The following is a description of a gene set: Genes containing one or more binding sites for (Pcgf3) in their promoter regions (TSS -1000,+100 bp) as identified by GTRD version 20.06 ChIP-seq harmonization. from publication Yevshin I, Sharipov R, Kolmykov S, Kondrakhin Y, Kolpakov F (PMID 30445619) studied in species Mus musculus Mouse Gene Set: PCGF3_TARGET_GENES, and this is the list of marker genes: Gm9758, Fbh1, Dnajb14, Ttc39d, 4930447C04Rik, Coprs, B3galt6, Gm15564, 5930430L01Rik, Rad9a, G730013B05Rik, Trip6, Tex101, Zc3h4, Atp6v0b, Rrn3, Dpp7, Dnajb9, Klhl22, Atp6v0d1, Natd1, Cib1, Hdac2, Cers6, Rpp38, A230060F14Rik, 6430548M08Rik, Scarna2, 4933434E20Rik, Hapstr1, Gm25894, Snhg9, Tmem108, Blm, Dcaf13, 8030453O22Rik, Vps26a, Ccdc103, Hoxa4, Prelid1, Osgep, Nup50, Rasgrf2 (NCBI Gene Id 70739), Cmc1, Mir5625, Rasa2, Gm12743, Fbxl2, Slc3a2 (solute carrier family 3 (activators of dibasic and neutral amino acid transport), member 2), Uhrf1, Fig4, Trim37, Gm16894, Pip4p1, Cdkl3, Atg14, Vps8, Uvrag, Aimp1, Ankrd16, Tgfa, Srsf2, Anxa6, Prmt9, Abhd17b, Snord2, Lamp1, Atp8b2, Tcam1, Synrg, Rnf130, Ighv8-14, Ubap2, Repin1, Gtf2h1, Podxl2, Aars1 (alanyl-tRNA synthetase 1), E2f6, Neurog1, Henmt1, Clcn6, Bnip3l, Pcx, Cep162, Dohh, Tmcc1, 1700122E12Rik, Hmox1 (heme oxygenase 1), Rnf212, Gpatch3 (G patch domain containing 3), Ubtd1, Orc4, Sumf1 (NCBI Gene Id 58911), Calcoco1, Tff3, Gstm2, A330048O09Rik, Rnf227, Pou2f1, Gm10555, Fam171b, Sf3b1, Gm8357, D430019H16Rik, 4930445N08Rik, Ttk, Mgam, Gm6288, Ip6k1, Hsd11b1, Dennd6a, Gba1 (glucosylceramidase beta 1), Chchd3, Zfp292, Gm11399, Npl, Gpc2, Pstpip2, Odad4, Prkar2a, Catsperg1, Tbck, mt-Co1, Bcas2, 2810408I11Rik, Hsf5, Platr30, Sub1, Gm25362, St6galnac3 (ST6 (alpha-N-acetyl-neuraminyl-2,3-beta-galactosyl-1,3)-N-acetylgalactosaminide alpha-2,6-sialyltransferase 3), Atg5, Fam178b, 1700001L05Rik, mt-Td, 6820431F20Rik, Spata31e2, Washc5, Nptn, Mettl5os, Bcl6, Scyl3, Echdc2, Ulbp1, Sec11c, Poldip3, Ddx5, Tdg, Ncl, Ccnb3, Ccar1, Clk4, Ighv1-67, Aspa, Micu1, Pbxip1, Piwil2, Atosa, Ctsb, Cln3, Cd164, Hspbap1, 3110082I17Rik, Mir7688, Sdf2l1 (NCBI Gene Id 64136), Lamtor5, Vapa, Commd4, Senp8, Satb2, Hoxd10, Fbxo25, C87436, Nr5a1, Fbxw4, Nup85, Psme3ip1, Neat1, 1700028E10Rik, Glb1, Prkacb, Srsf3, Myl12a, 4930535L15Rik, Mbtd1, Slc33a1, Stag3, Gm22711, mt-Tq, St13, Napa, Sgo1, Matr3, Ccdc115, Mapre1, Mir5627, Gm17259, Gm10463, Fkbp6, Prkcsh, Trpm7, Osbpl7, Sc5d, Tmem143, Cdk4, Mfsd1, Laptm4b, Agtrap, Tfap2c (NCBI Gene Id 98784), Stk4, Washc2, H2bc8, Med28, Glyr1, Phc3, Mtch1, Tmppe (transmembrane protein with metallophosphoesterase domain), Zfp280d, Csdc2, Ptprs, Ccdc124, Tex12, Alg1, Trpm8, Lcp2, Smap1, Gm16853, Ubb, Top1, Sec62, Exoc1, Tsen2, Mapk8, Khdrbs1, Atpaf2, Adgrv1, Atg13, Krt9, mt-Nd6, Nrxn1, 5830411K02Rik, Haus3, Boll, Commd8, Gpr176, Oas1b, G530011O06Rikx, Sdf4, mt-Tc, Wwp2, Rpl3, Rnu11, Gnpda1, Slc25a32, Nup188, Nrip3, Net1, Tdrkh, Relb, Selplg, Slc35a5, Gm19705, Ptp4a1, Lhfpl2, Rad50 (RAD50 double strand break repair protein), Smchd1, Mtch2, Cyba, Gm5893, Cox18, Ccdc13, Stmn1, Snora21, Dusp7, Bax, Alyref, 4930539M17Rik, Xpnpep3, Slc9a1, Depdc1b, Stt3b, Slc35g2, Ankrd24, Hmgn3, Mief2, Zfp747l1, Por, Rabl2, Cul5, Gm16675, Ctsl, Espl1, Vgf, Cc2d1a, Cnpy2, mt-Tm, Gm8379, Rhpn1, Mrpl27, Xrra1, 1700030C10Rik, Rnasek, Syngr4 (NCBI Gene Id 80661), Tex14, Otud1, Mir6978, Mks1, Zmiz1 (NCBI Gene Id 328365), Tbccd1, Phc2, mt-Nd5, Srd5a1, Cipc, Rbm19, 2310043M15Rik, Smim23, Gm2762, Fau-ps2, Gm2788, Zfp998, Slc49a4, Brme1, Deaf1, Vps33a, Rps28, Tnrc6c, Sppl3, 3000002C10Rik, Or4c119, Tmed2, Ctns, Meiosin, Lrrc27, Tmem19, Gad1, Zfp786, Zfp386, Hmgcl, Slc6a20a, Slc12a7, Harbi1, Ube2b, Imp4, Mir466j, Mir294, Begain, Or11m3, Paip1, Sae1, Haglr, Hdlbp, Fam241b, Tbc1d20 (TBC1 domain family, member 20), Mthfr, Pycr2, Rfesd, Itln1, Hspa9, Mei1, Cul3, Ttc3, Gm24016, Igfbp4, Pla2g12a (phospholipase A2, group XIIA), Ccnyl1, Kdm4c, Derl3, Kmt5c, Fndc3a, Togaram1, Spns1, Pxt1, Gm2093, Gdpgp1, Ppp1r3b, Bsg, Rragc, Gtf2a1, Tle6, Spin1, mt-Th, Stk25, Pcbp1, Tmem131, Kbtbd6, mt-Tv, Gm5067, Whrn, Dnase2a, Smyd4, Pdcd6ip, 4632404H12Rik, Amdhd2, Ighv12-2, 4930469K13Rik, Paxip1, Gmfb, Ybx2, Lmtk3, Rabl6 (RAB, member RAS oncogene family-like 6), Naxe, Dync1i1, 1600020E01Rik, H2bc18, Supt16, Gna15, Atp6v0e, Ddx4, Tnfrsf8, Ubr4, Rab11fip1, Hoxb7, Spcs2, Commd6, Hoxa7, Prmt3, Mir5100, Ccnh, 2900093K20Rik, Eif3b, Flvcr2, Tbkbp1 (NCBI Gene Id 73174), 5730420D15Rik, Gm13238, Rpl13a, Top6bl, Osbpl8, Pmm2 (phosphomannomutase 2), Eif3k, Cacul1, Ptbp1, Gpat2, 1700040D17Rik, Eef1a1, Hepacam2, Zic2, Rprd2, Nrdc, Spryd4, Poln, Zfp57, Rmc1, Brap, Gm43391, Cep95, Prex1, Gm26306, Gadd45b, Adamts6, Ilf3, Insm2, Idh2, Mir6236, Mfsd11, Spring1, Tmem80, Gar1, Ier2, Gnas, Syngr1, Mcm2, Eid1, Brox, Galt, Anln, Serf1, Scamp3, Rpl19 (ribosomal protein L19), Aatf, Blvrb, Apex1, Ppm1a, Snhg3, Or6c8b, Odad3, Slc24a4, Gm15538, Acsf2, A230083N12Rik, Coil, Ogdhl, Mir8101, Ndufa7, Ctsd, Col12a1, Faf1, Tmbim4, Selenoh, Abcc10, Dhx32, Rmi1, Cfdp1, Duxf1, Hexa, Zfp207, Dolk, Hectd3, Tug1, Fam117b, Hmgcr, A430005L14Rik, Snx32, Cfap251, Gm30238, Mid1, Foxred2, Tbc1d13, St8sia1, Tmc6, Pou6f1, Eif4e, Zfyve26, D030028A08Rik, Gbx2, Lypd1 (NCBI Gene Id 98472), mt-Tn, 1700110I01Rik, Cdip1, Fbxw19, Malat1, Wdr62, Slc38a7, Gm38250, Rabep1, Pelp1, Mlf1, Mepce, Rragb, Phf20, Mir293, Gm22489, Ubxn4, Hook2, Oser1 (oxidative stress responsive serine rich 1), Tbc1d15, Icos, Ccdc9, Auts2, Atl2, Zbtb32, Depdc7, Dph1 (NCBI Gene Id 74993), Srebf1, Ogfod2, Dusp18, Mapre2, Mterf3, Ccdc22, Xndc1, Nat10, Gm15050, Cd2bp2, H2ac21, Fam217b, Slc4a5, Prrc2c, Adissp, Wdfy1, Mrps9, Ndel1, Gm10837, Dyrk1a, Acot4, Actn2, Slc25a31, Lztfl1, Gapdh, Armc9, Acox1, Gm23143, Sike1, Gdpd1, Mir8099-1, Gon7, Wbp2, Mrpl2, Syt6, Atp6v1h, Runx1, Gm20005, Gm37450, Arih1, Rspry1, Gm15247, Slf2, Naglu, Map4k1, Orai2, Zc3h10, Gtf2h5, Ccdc150, 4930474N05Rik, Endov, Nudcd3, Rusc1, Il3ra, Irx3os, Gadd45g, Gm26608, Slc51a (NCBI Gene Id 224113), Pitx2, Usp28, Nfat5, Slc9a2, Gtf3c6, Qtrt1, Rnft2, Dixdc1, Gm13158, Swi5, Il1r2, Ubap2l, Irs2, Dnajc8, Gm24641, mt-Ts2, Armt1, Eif4a1, Chaf1a, Helq, Gas2 (growth arrest specific 2), Nuak2, Zfyve16, Trim25, Hoxc13, 4930556J24Rik, Mtdh, Insig1, Mccc2, Rpa1, Tor1aip2, C130036L24Rik, Khsrp, Wt1os, Fanci, Scn5a, Slc20a1, Vps16, Gm3242, Ift46, Rimoc1, Zpbp2, Stx6, Tssk3, 1700113A16Rik, Pdcd2l, Nme6 (NCBI Gene Id 56803), Supv3l1, Dio3, Eif1, 9430038I01Rik (NCBI Gene Id 77252), Fam53c, Cdca7l (NCBI Gene Id 217946), Crebrf, Ndufa8, Rcbtb1, Dvl2, Ythdf1, 1110059E24Rik, Gm26504, Depdc1a, Zfp36l1-ps, Uchl1, Cpm, Ccdc91, Gas5, Nop2, Bloc1s1, Ints6, Rab3il1, Pradc1, Epg5, Cdk20, Gnb2, Zan, Msantd5l, Trmt10a, Laptm4a, Irak3, Tmem126b, Ten1, Snora78, Plcg2, Dyrk1b, Slc25a33, Mob1b, Pcm1, Hormad1, Fbxo7, Vps50, Nagpa, Derl1, Gm16599 (NCBI Gene Id 105244801), Rpl26, Gm2822, Eef2, Rab24, Ugp2, Bicd1, Anapc11, Igf2r, Prpf39 (NCBI Gene Id 328110), Snora73a, Vdac2, Slc36a1, Sfi1, Tyms, Zfp990, Srsf7, Tnfaip3, Dazl, Septin2, Trim44, B3galt4, Slc12a6, Cnppd1, H2ac8, Gm25855, Snrpa, Eif3a, Duxf4, Pepd, Gm16149, Cmklr1, Adgra2, Prelid3a, Golga2, Mttp, Megf9, Slc37a3, Ubn1, Gse1 (NCBI Gene Id 382034), Rad51b, Epo, Best3, Smc3, Dpagt1 (dolichyl-phosphate N-acetylglucosaminephosphotransferase 1), Isl1, Prl2c3, Akap11, Ptpdc1, Kcnd3os, Hspa8, Hnrnpa3, Gcat, Zfp385b, Gm11400, Ssbp4, Tpp1, Lsm1, Ube2q1, Slc26a2, Snord3a, Spata16, Rtcb, Gm22357, Dhx40, Chsy1, 4933427E13Rik, Uqcc6, Eif4g1, Plbd2, Mov10l1, Tex10, Sde2, Rcan1, Rbm46os (NCBI Gene Id 78212), Tdrd1, Firre, Mms19, Wbscr25, Gm22039, Prpf3, Akap10, Snord104, Myo9a, Tubb5, Wdr81, Mrps18c, Diaph3, Aldh3a2, Eif5a2, Atic, Ppcs, Bola1, Cyth3, Hsd17b13, Mien1, Oasl1, Intu, Dhx35, Rbm46, Rps23, Pias4, Ciart, Zfp988 (NCBI Gene Id 666581), Lrrc8d, Slmap, Irf9, Tmem53, Gm20426, Kat5, Vps26c, mt-Tl2, Slc35b1, Thumpd2, 1700112D23Rik, Cdk5rap3, Slc25a21, Nsmce2, Cry1, Tfap2a, Trp53inp1, Sgta, Ube4b, Gins2, 3110040N11Rik, Lactb2, Grcc10, Serf2, Gm13136, Ankrd12, Nptx1, Mir295, 3110083C13Rik, Eftud2, Cd68, Rpsa-ps3, Zbtb24, Hnrnpk, Rap1gds1, Thoc3, Speer4cos, Tsc1, Gpsm2, mt-Tw, Fam118b, mt-Tp, Adh6a, Utp18, Actrt2, Mir1946a, Gm34086, Smndc1, Gm10614, Mapk6, Cacna1a, Serac1, Apba3, Gm12279, Gm25794 (predicted gene, 25794), Tti2 (TELO2 interacting protein 2), Abca1, Pbx3, Gm19265, Gm21978, Syce1, Gm24890, Kdm6a, Kcnd3, Sgsm1, E030030I06Rik, Zfp334, AA465934, Mtarc2, Gm26590, Snord43, Pigp, Abcg2, Hps5, Mul1, Actmap, Morn5, Hopx, Hmgn2, Adh5, Zcwpw1, Gm22513, Ddx11, Arl2, Frmd8os, Gpx1, Btbd18 (BTB domain containing 18), Tbc1d5, Hdac5, Rab3gap2, Lmx1a, Socs2, Comtd1, Gm17244, mt-Te, Mettl1, Arsa, Magt1, Fmnl3, Ncapg2, Hnrnph2, Pip4k2c, Fbxo33, Git2, Fdxr, Cep63, Hivep2, Gm24452, mt-Nd1, Zbtb40, Tmeff2, Dusp11, Snord13 (small nucleolar RNA, C/D box 13), Gtf2f1, Cdk8, Rmnd1, Cc2d1b, Urgcp, Dip2b, Klf2, Nudt9, Ak9, mt-Rnr2, mt-Cytb, Mrpl54, Gm15543, Dnajb11, Stk31, Hps3, Med31, Nsun2, Trappc8, Camk2d, Gga2, Taf1c, Gorasp1, Gm6089, Akip1, Neurl2, Gaa, Defa24 (defensin, alpha, 24), Rec114, Msh5, Gm15326, Mcoln1, Rbbp6, Cwc25, Micu2, Commd9, Urod, 4933424N20Rik, Lrrc9, H2ax, Ralgapb, 0610040J01Rik, Dlg1, Xpa, Xntrpc, H3c6, Eapp, Idua, Zmynd12, Agpat5, Ighv4-2, Usp31, Sox7, Gm10222, mt-Ty, Smarcc1, Vac14, Lamtor1, Gns, Adam10, mt-Ta, Gm13135, Gm10029, Gm13034, Retreg2, Rcc1, Ahcyl2, Cuta, Clcn7, Lnpk, Rnf121, Zfp507, mt-Tt, Rab21, C230037L18Rik, Dynlt2b, Klc4, Gucy1a2, Eef1akmt3, mt-Co2, Anapc13, Hsd17b2, Rbbp8, Thrap3, Atp6v1c1, Mlx, Skint11, Zbed5, Mydgf, Atxn3, B3galnt2, Ap5z1 (adaptor-related protein complex 5, zeta 1 subunit), Kdm3a, Psmd12, Ece1, Snora64, Dynlt1b, Zzz3, Marchf8, Eif4a2, Gm13228, Mafg, Hdac4, Map3k12, Sap25, Gm11762, Pfkfb2, Agbl5, Gm17115, mt-Tl1, Rps20, Gm26224, Car14, Slc35e3, Gla, Sema4b, Brdt, Lipe, Vps11, Meioc, Wdr19, Aida, Zmym6, Fosl2, Oxnad1, Zfp871, Gabarap, Tef, Stpg2, Dph3, 1700029M20Rik, Uchl1os, Usp30, Ralb, Plekhg4, Rps11, Gm17382, Krtcap3, Tnpo2, Zfp64, Rps24, Med13, Gid4, Metap1d, Atg3, 4921536K21Rik, Ubxn1, Zfp318, mt-Nd2, Dctn4, Rpl23, Shmt1 (serine hydroxymethyltransferase 1 (soluble)), Tmed10, P4ha2, Rps2, Rdh5, Cops7a, Ttc21a, Gm21847, Sec23ip, Vps37b, Nup54, Ano6, Sigmar1, Prr19, Psmd9, Slc35f6, Slc39a14, Rcn2, Acrbp, 1110060G06Rik, Prr23a2, Rab3gap1, Zbtb37, Stat3, Dnajc13, mt-Ti, Hoxd1, Hps1, H3f3b, Klhl28, Wee1, Shpk, Ccdc116, Ttc14, Trpv2, Eme1, 2610005L07Rik, Ctsa, Gm15539, Fdx2, Uqcc2, Rpusd4, Hnrnpd, Rab5a, Morc2a, Gm29856, Wnt5a, Alkbh7, Calr, Frmd4b, Mir5122, Mbd5, Spop, Tasp1, Arhgap12, Mrpl36, Brd2